The following is a description of a gene set: Genes predicted to be targets of miRBase v22 microRNA mmu_miR_6957_3p in miRDB v6.0 with MirTarget v4 prediction scores > 80 (high confidence targets). from publication Chen Y, Wang X (PMID 31504780) Mouse Gene Set: MIR_6957_3P studied in species Mus musculus, and this is the list of marker genes: Btbd35f23, 4930524B15Rik, Galr2, C1qtnf3, Qki, Mapk13, Or5b95, Trhr, Nol6 (NCBI Gene Id 99993), Fzd1, Gnrhr, Atxn1l, Gsk3b, Isl1, Chdh, Gm14296, Gm14322, Slc25a4, Top1, Trabd2b, Aktip, S100a10, Mrgprb2, 2210418O10Rik, Tiam1, Ogdh, Zfp1005, Zfp933, Samd10, Wars2, Rcn1, Birc6, Rab3c, Lemd1, Tet1, Pygo2, Serpinb7, Rpgrip1, C5ar1, Spn, Csf3r, Efna5, St3gal4, Ptpn5, Tmem170b, Ppp1r2, Ngfr, Xpnpep3